The following is a description of a gene set: species: Mus musculus Mouse Gene Set: GOBP_REGULATION_OF_ATRIAL_CARDIAC_MUSCLE_CELL_MEMBRANE_REPOLARIZATION Any process that modulates the establishment or extent of a membrane potential in the polarizing direction towards the resting potential in an atrial cardiomyocyte., and this is the list of marker genes: Scn5a, Kcna5, Kcne5, Flna, Kcnq1, Nppa, Cacna1d